The following is a description of a gene set: species: Mus musculus Tandem pore domain potassium channels Mouse Gene Set: REACTOME_TANDEM_PORE_DOMAIN_POTASSIUM_CHANNELS, and this is the list of marker genes: Kcnk16, Kcnk1, Kcnk13, Kcnk7, Kcnk10, Kcnk9, Kcnk3, Kcnk6, Kcnk4 (potassium channel, subfamily K, member 4), Kcnk2, Kcnk18